Given this list of marker genes PPP5C, KCTD20, ZDHHC2, TSPAN9, ADAMTS7, SLIT1, PDGFRB, ELMO2, MMP7 (matrix metallopeptidase 7), GFUS, ACACB, CCDC3, CCDC80 (NCBI Gene Id 151887), APOD, BLOC1S1, SERPINF1, PIH1D1, TMEM107, OLFML3, RITA1, ACTN4, NDRG2, SOAT1, SPARCL1, DAND5, PSME1, here is a description of the gene set: Activated forms of Ras family members are prevalent in many cancers where Ras mutants transduce signals essential for transformation, angiogenesis, invasion and metastasis. As a cancer progression model, we used NIH3T3 cells to explore the mechanism of Ras-induced tumorigenesis. Ras family mutants H-RasV12 and Rit79L strongly induced foci formation, while Rho family mutants RhoA-QL, Rac1-QL and Cdc42-QL were less effective. A comparison of downstream transcriptional targets of Ras and Rho family members using a 26 383 element cDNA microarray revealed that the osteopontin (OPN) gene exhibited the best correlation between magnitude of gene expression change and level of foci formation (r=0.96, P<0.001). In association with H-RasV12- and Rit79L-mediated transformation, foci secreted OPN protein and upregulated the OPN receptor CD44, suggesting the novel initiation of an aberrant OPN-CD44-Rac autocrine pathway. In support of this were the following observations. First, RGD-deficient OPN protein-binding activity was present in H-RasV12-transformed cells but not in control cells, and binding activity was inhibited by the CD44 blocking antibody. Second, foci formation, cell invasion and Rac activity were induced by H-RasV12 and inhibited by the CD44 blocking antibody. Third, foci formation by H-RasV12 was substantially reduced by a short interfering RNA (siRNA) specifically targeting OPN expression for knockdown. Fourth, H-RasV12-mediated transformation was not blocked by the GRGDS peptide, suggesting that OPN effects were not mediated by the integrins. Lastly, OPN knockdown affected the downstream expression of 160 '2nd tier' genes, and at least a subset of these genes appears to be involved in transformation. Indeed, four genes were selected for knockdown, each resulting in a disruption of foci formation and/or invasion. These results underscore the role of aberrant autocrine signaling and transcriptional networking during tumorigenesis. Cluster 6: genes exhibiting prolonged up-regulation (>72 h) after knockdown of OPN by RNAi in the NIH3T3 cells (fibroblasts) transformed by activated HRAS. studied in species Mus musculus Human Gene Set: TERAMOTO_OPN_TARGETS_CLUSTER_6 from publication Teramoto H, Castellone MD, Malek RL, Letwin N, Frank B, Gutkind JS, Lee NH (PMID 15516973)